The following is a description of a gene set: species: Homo sapiens The progression of the respiratory system over time from its formation to its mature structure. The respiratory system carries out respiratory gaseous exchange. Human Gene Set: GOBP_RESPIRATORY_SYSTEM_DEVELOPMENT, and this is the list of marker genes: SOX11 (SRY-box transcription factor 11), HOPX, RBP4, RBBP9, MSX1, MAPK3, THRB, CCBE1, FGF18, SPDEF, PHOX2B, EVA1A, SLC23A1, WT1, ASCL1, LOXL3, COL3A1, PDGFA, RDH10 (NCBI Gene Id 157506), TP73, RPL13A, BMP4, MAPK1, MAP2K2, SPRY1, NOS3, EDN2 (NCBI Gene Id 1907), SHH (NCBI Gene Id 6469), MAN1A2, SIX4, NKIRAS2, SAV1, CLCN2, CTSZ, TBX5, LTA4H, HOXA5, GLI2, EDA, HMGCS2, DNAAF3, STK40, HMGB1, PDPN, PKDCC, MMP12, WNT11, EXT1, LEF1, MMP14, RC3H2, TCF21, ZFPM2, FBN1, BAG6, MSC, FGFR2, PLOD3, ELK1, FKRP, ACVR2B, SIM2, CHI3L1, LOX, SEC24B, HHIP, FGF2, SPEF2, SMPD3, VEGFA, WNT7B, NFIB (NCBI Gene Id 4781), SPRY2, ANXA2, ITGA3, SOX9, TNC, COL6A1, IGF1, HMGA2, IL13, FOSL2, FOXJ1, ABCA3 (NCBI Gene Id 21), FOXP2, GSTCD, TGFB3, EP300 (E1A binding protein p300), FOXA1, FLT4, MOSMO, ASS1, PPP3R1, NKIRAS1, TAB1, LHX3, MIR17HG, PGR, SFTPD, ERRFI1, FGF8, PHEX, MAP2K1, TGFBR2, ASXL1, SRF, HIPK2, ID1, HYDIN, CIC, SREBF1, SMAD2, AGR2, HESX1, FGF7, JMJD6 (jumonji domain containing 6, arginine demethylase and lysine hydroxylase), WDPCP, ALDH1A3, LTBP3, SLC7A11, WNT5A, GLI1, BMP2, TGFB1 (NCBI Gene Id 7040), CTSH, GPC3, PDGFRA, BLOC1S6, RSPO2, TNF, CRH, TBX4, BMPR2, MYCN, RARA, TBX2 (T-box transcription factor 2), RARG, THRA, MYOCD, YAP1, WNT2, HIKESHI, LAMA1, IGFBP5, DNAAF1, ITGB6, HEG1, CEBPA, ZIC3, BASP1, CREB1, ATP7A, HSD11B1, IFT25, CHD7, LIF, SMCHD1, ADAMTS2, PPP1CA, GNG8, BMPR1A, FGF10, NKX2-1, MAN2A1, LIPA, CTNNB1, DLG5, CYP1A2, ADA, TMEM38B, SELENON, TIMELESS, NKX2-8, KRAS, NOTCH1, RCN3, CDC42 (NCBI Gene Id 998), FGF9, RAB3A, GRHL2, PTK7, ADAMTSL2, ATXN1, FGF1, PKD1, HS6ST1, PROX1, SP3, KDR, DAG1, HES1, YWHAZ, FGFR1, CCDC39, ALDH1A2, PHF14, GATA6, RXFP1, CCN2, WNT2B, DLX5, FOXF1, CELSR1, DISP1, ABCA12, SRSF6, VANGL2, EPAS1, MME, RBPJ, SKI, LAMA5, ESRP2, CLDN18, FGFRL1, RPGRIP1L, KLF2, CRISPLD2, ODAD4, GLI3, TULP3, ATXN1L, AP3B1, CCDC40, AIMP2, NPHP3, STRA6, NODAL, NOG, PITX2, SIX1, DPPA4